The following is a description of a gene set: studied in species Homo sapiens Human Gene Set: GOMF_ATPASE_BINDING Binding to an ATPase, any enzyme that catalyzes the hydrolysis of ATP., and this is the list of marker genes: TAF9, NPLOC4 (NCBI Gene Id 55666), SRC, VCPKMT, SELENOS, AR, SVIP, ATOX1, TUNAR, TMTC4, ATP5IF1, NR1H2, TOR1AIP1, RUVBL1, ABCA1, ATP6V0A1, DNAJC10, USP25, PEX26, SNURF, NKD2 (NKD inhibitor of WNT signaling pathway 2), ATP1B3, METTL21A, FXYD3, NKAIN1, PDE4D, SYVN1, EGFR, LCK, SNU13, RALA, CAV1, RUVBL2, TRPC5, ZNHIT6, RALB, NUFIP1, EZR, S100A1, ATP6V0A4, ATP1B1, NOP58, ATP6V1E1, CLPP, PSEN1, SLN, CHMP4A, NCSTN, ADCY10, ALDOB, SDF2L1, TCIRG1, HRC, WFS1, PLN, ANK1, TMEM106B, DBNDD2, FXYD7, ATXN3, GABARAPL2, SLC26A9, BRSK2, TRPC1, ESR1, UBXN1, FBL, TRPC6, PEX19, PTPN3, DNAJB1, ANK2, PIH1D1, ATP1B2, PKD2, ATP6V0A2, TOR1AIP2, ATP6V1G3, SNX10, RDX, ATP6V1G1, SLC2A13, PGR, DERL1, PPP3CA, BBC3, FXYD4, SNTA1, UBXN6